Given this list of marker genes CACNB4, PLXNA4, ARHGAP18, SLC38A1, NEUROG2, NECAB1, IRS1, LPP, RAB23, VASH2, MEF2C, ITPR1, USP30, PDCD6IP, PRSS23, TFDP2 (transcription factor Dp-2), HERC2, SLC15A4, HSPA12A, USP51, TMEM232, MAGI1, DYNC2LI1, KHSRP (NCBI Gene Id 8570), COL14A1, DMTF1, C8orf44, WDR89, NABP1, RHOBTB3, MOB2, ATRN, ZNF264, PAQR8, TMEM182, CTBP2, APPBP2, HAND2, MATR3, AMPH (amphiphysin), SDCBP, FMR1, UBE2D3, NCF4, RBMS3, MBNL1, ZNF221, POU2F2, SLC25A5, DDX21, TOMM6, GALNT1, ADAMTS9, NAV1, CPEB3, MRPL49 (NCBI Gene Id 740), CNOT9, ZFP3, KLF12, RABGGTB, TRAPPC9, RSF1, PDK3, LURAP1L, GAPT, ZKSCAN8, GPR75, SEC61B, KCTD21 (NCBI Gene Id 283219), RUFY3, MNAT1, C5orf24, ODF4, ATG3, GEMIN5, LRIG2, MACROD2, B3GAT2, DBT, UFM1 (NCBI Gene Id 51569), ZNF460, CSGALNACT2, CDK6, PATZ1 (NCBI Gene Id 23598), PFN2, NRK, AGPAT3, ACADSB, TM9SF2, PMP22, NSD2, TIMM8A, OTX2, C17orf49, DCUN1D2, SPATA9, ENY2, NR3C1, CD164, P4HA1, TMEM47, NCKAP1, CR1, GFM1, SLC1A6, ZDHHC2, DIP2B, UBE2G1, TCEAL4, GABRA1, SH3RF1, SLC4A9, ZNF124, NUDT11, TMA16, MUCL3, NAV3, PGM1, PLCG2, DHX38, ARHGAP28, ZNF800, PDE4D, MAPKAPK3, GALNT7, CDC42EP3, WWC2, SERPINB12, HFE, DDI2, LSAMP, TMA7, ZDHHC7, ZNF189, AKAP5, DYNAP, DCLK1, SLC5A1, HMGCLL1, RUNDC3B, MOBP, TCEAL8, CASTOR3P, CPNE3, here is a description of the gene set: Human Gene Set: MIR1245B_3P from publication Chen Y, Wang X (PMID 31504780) Genes predicted to be targets of miRBase v22 microRNA hsa-miR-1245b-3p in miRDB v6.0 with MirTarget v4 prediction scores > 80 (high confidence targets). species: Homo sapiens